The following is a description of a gene set: species: Homo sapiens Irregular hyperpigmentation Human Gene Set: HP_IRREGULAR_HYPERPIGMENTATION, and this is the list of marker genes: FGFR1, RAD51C, CYBC1, PHIP, FANCD2, SKIC3, CWC27, LYST, FGFR3, CHN1, BLM (NCBI Gene Id 641), ATM, CYBB, MAPRE2 (microtubule associated protein RP/EB family member 2), BRCA2, IL6, H4C5, KIT, PDE11A, FANCI, ANAPC1, TMC8, KRAS, SLC9A1 (NCBI Gene Id 6548), POLE, CDKN1B (NCBI Gene Id 1027), ATP2A2, CBL, KRT5, REV3L, CDKN2B, UBE2T, GJA1, ACTB, GNAQ, GJB4, XPA, ERCC1, MSH6, CDKN1C, TUBB, PLAG1, RERE, TWIST2 (twist family bHLH transcription factor 2), IKBKG, NHP2, BRCA1 (NCBI Gene Id 672), FERMT1, TAF4, CRIPT, ZMPSTE24, GPNMB, RBBP8, TERT, NCF1 (NCBI Gene Id 653844), MED12, RAD51, MAP2K1, ARL6IP6, SOX10, SLX4, CREBBP, SMARCAL1, SDHA (NCBI Gene Id 6389), TMC6, CYBA, PMS2, CHD8, BRIP1, POLA1, SRD5A3, PDGFRB, SDHB, COPB1, RET, TINF2, TSC1, FANCB, NCF4, APC, BUB1, MAN1B1, TP53 (tumor protein p53), MAFB, IL7, SET, PORCN, PTEN, HRAS, DDB2, INSR, PALB2, XPC, MLH1, WASF1, SEC23B, WBP11, CDKN2C, SMARCAD1, SPRED1, CTC1, KRT14, KMT2D, PLXND1, GNAS, PRKAR1A, TP63, SDHD, COL3A1, NPM1, GNA11, MAD2L2, AKT1, KANSL1, C1S, FANCE, NCF2, NF1, IGF2, XRCC2, C1R, SMARCA2, CIB1, CTLA4, RPA1, ERCC8, PIK3CA, CLCN7, POFUT1, WRAP53, COL7A1, ACP5, COL17A1, EP300, UBAP2L, CARD14, POGLUT1, FANCC, DNASE1L3, TNFRSF1A, MEN1, MMP2, ANKLE2, DSTYK, MAPK1, NBN, TERC, GJB3, CASR, CDKN1A, SASH1, SHOC2, DHX30, FANCL, BANF1, HGD, CD28, TOP3A, MPV17, FANCA, SALL4, RFX7, PSENEN, NF2, RTEL1, CAPRIN1, IGF1 (insulin like growth factor 1), MAP2K2, USB1, TYMS, BUB3, NOP10, LZTR1, SPINK5, HMGA2 (high mobility group AT-hook 2), GNB2, CLTRN, SDHC (NCBI Gene Id 6391), PCNT, TRIP13, KLLN, TSC2, BUB1B, FANCG, HEPACAM, SH3PXD2B, DKC1, UBR1, KITLG, TOMM7, SEC23A, ESCO2, SVBP, PDGFRA, MTOR, KDM6B, ERCC2, PTPN11 (NCBI Gene Id 84990), BPTF, ST3GAL5, IRF1, KDSR, TNFRSF1B, ABCB6, LBR, FANCM, USF3, FANCF, IFNG, ERCC4, ERCC5, LMNA (lamin A/C), KDM5C, RAF1, NRAS, PARN, SKIC2, VHL, PLEC, SLF2, ABCD1, NOTCH3, BRAF, ABCC9, TMEM127, NDUFB11, KDM6A, DDX11, SLC6A19, RFWD3, CEP57, MAX, TP53RK, PPP1CB, ERCC6, STEAP3, STK11, MSH2, ERCC3